Given this list of marker genes SYPL1, DHX15, GMCL1, CSGALNACT1, NAMPT, NAA35, SAMTOR, HIKESHI (heat shock protein nuclear import factor hikeshi), AFF3 (ALF transcription elongation factor 3), BCL2L12, ADAM10, SH3YL1, ZDHHC14, PIK3AP1, POP7, RSBN1, CYTH1, DNAJC7, C1orf52, PES1, MED6, LENG9, HEPACAM2, SLC41A2, SMAP2, CXCR4, SF3B1, ICOSLG, CDC5L, RMND1, TFEB, QKI, MON2, GATB, ZBTB48, VMA21, HNRNPU, ABCA5, LRCH1, SNHG32, ATP6AP1, TRNT1, SKIL, NFKBID, RPL31, MRPS7 (NCBI Gene Id 64967), RAB2B, AKAP7, GABRB2, RRM2B, ITPR3, LPGAT1, HSPA12A, STOML1, MGA, PRDX4, CHFR, CCNF, NIP7, YWHAG, SNHG6, ERCC6L, CIMIP6, FBXL4 (F-box and leucine rich repeat protein 4), ADAMTS15, YTHDC1, TGIF1, BRWD1, CNOT2, CYP51A1, METTL16, TAFAZZIN, CHD1 (NCBI Gene Id 1105), PANK4, RAB39A, MAPK11, DUT, VIM, SON, SH3BP2, STARD5, ST3GAL1 (NCBI Gene Id 6482), TMEM263, RDH11, SETDB2, SLC15A3, BRI3, MYO5A, MRPL34, PARG, DNA2, ERI1, UPB1, PRR18, MMGT1, B3GNT2, RNASEH2A, PPCDC, RBM34, CUEDC2, AGTPBP1, PTK2B, RBBP5, IER5, ZBTB7A, PCSK1, USP39, SERPINB7, CDT1, TRIM34, CPSF2, MSH6, SRSF7, CAT, DAZAP2, TEC (tec protein tyrosine kinase), PLEKHB1, LRRTM3, UBE2E1, NFAM1, PFKFB1, C2CD2L, HELQ, CHEK2, HYCC1, YEATS4, C9orf85, C16orf87, HEXIM1, MPP1, NEURL2, XRCC1, ATP2A3, USF3, MTMR14, RPP25L, ANKRD37, MED31, EIF1, PDE4B, RPA3, ACE, RPS25, BST1, PFDN4, PSME4, MEF2D, ACSS1, SLC2A6, NECAP2, RECQL5, PACC1, MTDH, CARHSP1, USO1, LANCL2, THOC3, KANSL2, FBXL6, TIRAP, RTCB, RHOA, TREML2, MATK, TRIM35, IDO2, VPS11, CXXC5, ZNF410, HES6, MMS22L, APC, AICDA, MBD3, PPIH, MED13, NFKBIE, ETHE1, IFT172, DIPK1A, KIAA1217, SLC38A9, RNF19B, PPP1R21, DNPEP, PIH1D1, THBD, SHARPIN, HSBP1, CMTM7, RDH12, TSSK2, CRIP3, UQCRB, DCUN1D1, MSN, PPIL6, SH3TC1, TRAPPC2L, STEAP2, here is a description of the gene set: species: Homo sapiens from publication Konuma T, Nakamura S, Miyagi S, Negishi M, Chiba T, Oguro H, Yuan J, Mochizuki-Kashio M, Ichikawa H, Miyoshi H, Vidal M, Iwama A (PMID 21540074) Human Gene Set: GSE27786_BCELL_VS_NKTCELL_UP Each fraction of mouse hematopoietic cells was purified by cell sorting from bone marrow of 8-week-old C57BL/6 mice, and its gene expression was analyzed. Genes up-regulated in comparison of B cells versus NKT cells.